The following is a description of a gene set: from publication Hooi CF, Blancher C, Qiu W, Revet IM, Williams LH, Ciavarella ML, Anderson RL, Thompson EW, Connor A, Phillips WA, Campbell IG (PMID 16474848) Genes down-regulated in PC-3 cells (prostate cancer) stably expressing ST7 off a plasmid vector. Human Gene Set: HOOI_ST7_TARGETS_DN studied in species Homo sapiens Multiple lines of evidence have provided compelling evidence for the existence of a tumor suppressor gene (TSG) on chromosome 7q31.1. ST7 may be the target of this genetic instability but its designation as a TSG is controversial. In this study, we show that, functionally, ST7 behaves as a tumor suppressor in human cancer. ST7 suppressed growth of PC-3 prostate cancer cells inoculated subcutaneously into severe combined immunodeficient mice, and increased the latency of tumor detection from 13 days in control tumors to 23 days. Re-expression of ST7 was also associated with suppression of colony formation under anchorage-independent conditions in MDA-MB-231 breast cancer cells and ST7 mRNA expression was downregulated in 44% of primary breast cancers. Expression profiling of PC-3 cells revealed that ST7 predominantly induces changes in genes involved in re-modeling the extracellular matrix such as SPARC, IGFBP5 and several matrix metalloproteinases. These data indicate that ST7 may mediate tumor suppression through modification of the tumor microenvironment., and this is the list of marker genes: ARF3, IREB2, MBTD1, ANKRD36B, ARMH4, ENO2, MAGEA3, DEPP1, APOBEC3G, AKR1C3, OBSL1, MIRLET7BHG, TM4SF1, PCSK1N, RBP4, CXCL16, ACSL3, PDK1, NFKBIZ, FOXA1, ZBTB47, TSPAN31, TCN1, C5, KMT5B, GUSBP14, SLC14A1, LINC00960, SRGAP3, MCOLN3, CDH12, TMEM30B, CNTNAP3, CCDC150, PAK3, VWA5A, TTN (titin), PAK6, GXYLT2, ARID2, RBPMS (NCBI Gene Id 11030), CLIP1, CEMIP, CCNG2, WNK3, PRKRA, ID2, PHEX, COL1A1, LINC00907, ETFA, TBC1D8B, SLC22A23, NDRG1, ZDHHC13, TRABD2B, ITPR1, NNMT, TRIB2, DNAH5, SYT17, PDLIM4, ITGB8, GPR160, SPARC (secreted protein acidic and cysteine rich), KLC1, NOG, TENT5C, CXCR4, FN1, NPTN-IT1, EPHB3, DENND1B, TMTC1, PPL, TP53INP1, SPRY4, ALK, DHRS2, CRIP1, WHAMMP4, CADPS2, PPFIA4, MGAT5, PFKFB4, PDK3, ZNF395, ANG, CCDC141, IGFBP5, TMEM45A, ANGPTL4, MMP10, TLCD4, RAP2A, MMP13, BAMBI, ENSG00000310519, CFAP96, NAA25, MLLT3, PGAP1 (post-GPI attachment to proteins inositol deacylase 1), EXOC6, PLA2G7, FAM131B, TPM4, MSANTD2, C2CD4A, STON1, CREB3L1 (NCBI Gene Id 90993), TSPAN8, PPP1R3B, TET1, MMP1, KDR, CSGALNACT1, MCAM, RNASE4